The following is a description of a gene set: part of: Activation of BH3-only proteins This event has been computationally inferred from an event that has been demonstrated in another species.<p>The inference is based on the homology mapping from PANTHER. Briefly, reactions for which all involved PhysicalEntities (in input, output and catalyst) have a mapped orthologue/paralogue (for complexes at least 75% of components must have a mapping) are inferred to the other species. Reactome Pathway: Activation of BAD and translocation to mitochondria studied in species Mus musculus electronically inferred by orthology from the curated human pathway, and this is the list of marker genes: Ppp3cc, Bad, Sfn, Ppp3r1, Ywhae, Ywhah